Given this list of marker genes Musk, Dock2, Helz, Pak4, Sgk2, Grk6, Igf1r (insulin-like growth factor I receptor), Camk2g, Mok (MOK protein kinase), Mthfs, Camk2b, Elp1, Lats1, Myo1g, Rasgrp2, Oas3, Ccdc88a, Kif7, Pik3c2a, Adcy10, Gna12, Dync2h1, Itpr3 (inositol 1,4,5-triphosphate receptor 3), Srp54a, Elmo1, Cdk12, Gnai3, Rab2a, Tut1, Kit, Acvr1c, Hspa5, Vcp, Dgka, Mtg1, Nadk, Slc27a2, Pals1, Gnal, Camk4, Abcb11, Dnhd1, Ippk, Sh3bp5l (NCBI Gene Id 79566), Tbck, Igtp, Slc27a3, Prkcg, Rasl12, Kdr, Ephb6, Rap2c (NCBI Gene Id 72065), Galk1, Rasgrp4, Ercc6l2, Myh7b, Kif2c, Atad3a, Rab21, Atp11a, Upf1, Ttll6, Recql, Myo3a (myosin IIIA), Smc5, Rabl2, Aasdh (NCBI Gene Id 231326), Ube2k, Rap2b, Ddx46, Abl1, Epha4, Ctps1, Cit, Gbp5, Ddx51, Tor3a, Ppp5c, Acta2, Cyth4, Cmpk1, Coq8a, Tubb4a, Arhgef17, Dnaja2, Wars1, Aqr, Dhx58, Ckmt1, Palm3, Blk, Mon1a, Bmx, Ric8a, Bag5 (BCL2-associated athanogene 5), Tubb4b, Ern2, Grk1, Cdk19, Mtif2, Top2b, Nlrp9c, Ptk2b, Dgki, Rasl11a, Prkaca (NCBI Gene Id 18747), Pip5k1b, Dennd3, Tdrd9, Anxa6, Ksr2, Srpra, Fer, Abcb9 (NCBI Gene Id 56325), Mat1a, Fgr, Clcn4, Slfn8, Mapkapk3, Shpk, Csnk1a1, Pik3r4, Rnasel, Cdk17, Kif21a, Cdc42bpa, Abcd3, Rapgef5, Gbp7, Mcf2 (NCBI Gene Id 17206), Nmrk1, Dgkg, Hras, Gimap9, Renbp, Zgrf1 (NCBI Gene Id 99630), Myo3b, Ddx49, Pink1, Erbb2, Abca3, Dclk3, Nubp1, Tyro3, Pak5, Trio, Kif27, Rin3, Arf5, Uba5, Septin4, Myo10 (NCBI Gene Id 52514), D5Ertd579e, Rab14, Eef2k, Rimklb, Tsr1, Gars1, Tssk1, Eif4a3, Qrsl1, Dyrk1a, Chkb, Rasgrf2, Akt1 (NCBI Gene Id 268604), Prex2, Uprt, Afg3l1, Stk19, P2rx5, Prex1, Oxsr1, Insrr, Rab8a, Fpgt, Arl4c, Tor1b, Coq8b, Pi4k2b, Rtel1, Mast1, Dis3, Epha2, Dgkh, Clp1, Net1, Dock5, Rad51d, Kifc3, Tcp1, Tdg-ps, Yars1, Ret, Dync1li1, Gucy2e, Stradb, Atp8b2, Epha8, Abca2, Hspa13, Cct5, Stk35, Tuba8, Prkg1, Lonp2 (NCBI Gene Id 66887), Ube2d2b, Rars2, Tuba1a, Lonp1, Dnah8, Actr1b, Ercc6, Ccdc88c, Mylk, Rasgrp3, Acly, Bag4, Slc22a4, Acvr1b, Actr3, Mapkapk5, Msh6, Ksr1, Chd7, Septin10, Gbp9, Gtpbp3, Rad54l2, Vrk3, Gnat3, Dyrk4, Clk3, Atp2c1, Trap1, Insr, Rcc1l (reculator of chromosome condensation 1 like), Cps1, Tbc1d10a, Ripk4, Itpkc, Selenoo, Rgl1, Cdk1, Septin9, Runx1, Ephb2, Rangrf, Smchd1, Prps1, Tuba1b, Rabgef1, Mink1, Cct8, Srprb, Eefsec, Eef1b2, Brsk1, Plk4, Nlrp1b, Mmab, Dync1li2, Hsp90b1, Rab3b, Rapgef6, Hlcs, Atp2b1, Nadsyn1, Pik3cg, Eif2b4, Papolb, Dennd11, Dennd6a, Hspa14, Adcy1, Gimap6, Ect2, Eif2ak3, Wnk1, Uck2, Prkcz, Abcd4, Mapk10, Phkg1, Acsm2, Rab6a, Rps6ka2, Septin1, Cftr, Slc22a21, D1Pas1, Top2a, Nlrc4, Ttll3, Preb, Wee2, Fes, Pip5kl1 (phosphatidylinositol-4-phosphate 5-kinase-like 1), Farp1, Msh5, Rab20, Mcm8, Pms2, Kif20b, Rhof, Ercc2, Rtcb, Actg1, Ttll10, Magi1, Rragc, Epha3, Tubb3, Pxk, Vrk2, Gem, Arl5b, Dock8, Dnah1, Rras2, Tk2, Twnk, Itpr1, Hltf, Pak6, Ddx20, Eif2s3x, Ak8, Ckm, Mapk1, Rfk, Kif1b, Trpm6, Septin3, Ttk, Sgk1, Eif2b2, Khk, Abca12, Caprin1, Rnd3, Rhod, Kif23, Eif2b5, Dgkq, Ddx24, Msh3, Ephb3, Cdc42, Tgm2, Jak1 (NCBI Gene Id 319959), Gimap1, Lrrk2 (NCBI Gene Id 79409), Gucy2c, Ckmt2, Thrap3, P2rx7, Dennd5a, Fgd3, Als2, Dck, Acta1, Camk1d, Dhx40, Ttll7, Bcs1l, Kif24, Ino80, Kif16b, Kif4, Rab3gap2 (RAB3 GTPase activating protein subunit 2), Rhoq, Map3k6, Nek9 (NCBI Gene Id 353030), Riok1, Arhgef4, Plk2, Rabif, Rragb, Suclg2, Asns, Atp2a2, Rrm1, Eftud2, Kif2a, Baz1b, Ddx11, Pbp2, Ube2j2, Arhgef15, Arhgef6, Npr2 (NCBI Gene Id 230103), Tdg, Rtca, Smarca2, Atl2, Papss1 (3'-phosphoadenosine 5'-phosphosulfate synthase 1), Arl6, Gnl3, Adcy4, Aatk, Tuba1c, Clcn6, Rem2, Plekhg5, Acacb, Rab22a, Ak4, Gnl3l, Speg, Myh8, Stk31, Naip5, Nlrc3, P2rx2, Tnk1, Wdr41, Lck, Carns1, Ruvbl1, Arl10, Smc2, Ralgds, Mtpap, Mov10, Dnm2, Rac3, Ttll1, Raf1 (v-raf-leukemia viral oncogene 1), Bms1, Tex14, Nme1, Atp8b1, Kif14, Lars2, Rab3ip, H1f4 (H1.4 linker histone, cluster member), Chd8, Cdk2, Mx2, Ercc6l, Atp8a1, Nek7, Rab7, Rab8b, Tkfc, Ube2z, Hps4, 4933405O20Rik, Mapk9, Ripk2, Cilk1, Morc2b, Map2k3, Nav3, Dhx29, Mark3, Mlkl, Sars2, Ak2, Hk1, Rp2, Rhoa (NCBI Gene Id 51787), Srpk1, Myo7a, Entpd3, Map4k2, Septin12, Recql5, Mycbp2, Hipk4, Rab32, Wee1, Rtkn, Ralgps2, Trpm4, Map2k1, Arl8a, Ptk6, Nwd1, Pik3c2g, Kcnj8, Gpn3, Ngef, Uckl1, Top1, Actr1a, Plekhg1, Lsg1, Nadk2, Skic2, Hars2, Myo15a, Rap1b, Tssk3, Abcf1, Abcb10, Ddx21, Qars1, Rab26, Mlh1, Rngtt, Gucy1b1, Dars1, Ntrk2, Ralb, Psmc6, Adcy8 (adenylate cyclase 8), N4bp2, Ppip5k1, Dhx30, Kras, P2rx3, Atp2c2, Cplane2, Dars2, Dnah17, Agap2, Hsp90ab1, Hspa9, Stk38l, Ercc3, Atp9b, Idnk, Nubp2, Dnmbp, Eps8l3, Hkdc1, Arhgef3, Rbks, Cct2, Slc22a5, P2ry1, Dennd1c, Nlrp4f, Kcnj10, Pank2, Xrcc5, Kif11, Atp10d, Tufm, Cyth3, Pik3c3, Kif5a, Braf, Epha10, Map2k5 (NCBI Gene Id 23938), Sh2d3c, Dhx34, Nek3, Rap1a, Eif5b, Mcm5, Dennd2d, Ntpcr, Camkv, Tdrd12, Dnm3, Nlrp4b, Rab36 (NCBI Gene Id 76877), Plcd4, Dmpk, Myo5a, Ep400, Arhgef10, Adcy6, Farsa, Nsf, Chrm4, Itm2c, Adcy2, Ttll13, Afg2a, Chuk, Rlig1, Gnat2, Pars2, Atm, P2rx1, Abcg1, Slfnl1, Katnal2, Adcy7, Naip1, Abce1, Ddx3y, Map2k6, Clk1, Sergef, Prkg2, Taf1, Pomk, Epha7, Lig4, Gna13, Drg2, Smc1a, Stk36, Psd3, Agap1, Arhgef18, Arl5c, Ube2m, Ltk, Pcx, Stk32c, Peak1, Rhobtb3, Rock2, Ttll11 (tubulin tyrosine ligase-like family, member 11), Abcc1, Abcc2, Abcc4, Gucy2f, Dnaja1, Snrk (NCBI Gene Id 97116), Fn3k, Tep1, Kif5c, Tap2, Kif15, Myo18a, Uck1, Afg2b, Tlk2, Samhd1, Yars2 (tyrosyl-tRNA synthetase 2 (mitochondrial)), Ddx28, Mtg2, Rad51, Txk, Ripk1, Magi3, Sbk1, Rrad, Hfm1, Timm44 (NCBI Gene Id 76268), Erbb3, Map4k5, Cdk11b, Etnk1, Ube2n, Plekhg2, Rhov, Pikfyve, Ube2h, Gna14, Ulk1, Ptpa, Sos2, Map3k11, Abca8a, Nlrp4a, Glud1, Hacl1, Sar1b, Gspt2, Dhx15, Entpd1, Lrguk, Oas1a, Hspa4 (heat shock protein 4), Runx2, Msh4 (mutS homolog 4), Bub1b, Kif5b, Ythdc2, Rraga, Smc4, Cdkl5, Pfn1, Dock7, Gnaq, Nuak1, Mylk3, Fgfr4, Abcd1, Rps6kb1, Rasgef1c, Mccc1, Pkmyt1, Arhgap35, Arl4a (NCBI Gene Id 11861), Clcn3, Hyou1, Dnaja3, Bub1, P2ry4, Ehd2, Flad1, Adcy5, Hnrnpu, Atl1, Nin, Rasl2-9, Sil1, Map4k1, Camk2a, Arfgef3, Dyrk2, Farsb, Rnd1, Nudt2, Tor4a, Sbf1, Ikbkb, Myo6, Ppip5k2, Ddx41 (NCBI Gene Id 72935), Gch1, Ttbk1, Atp8a2, Arf1, Pcca, Gpn2, Rapgefl1, Vps4a, Dicer1, Prkag3, Myo1a, Cct3, Camk1g, Eif2b1, Fastk, Rasl11b, Smarcal1, Aacs, Gnao1, Rasd1, Itsn2, Dennd4c, Rac2, Atp4a, Ube2b, Psd, Rad51c, Mthfsl, Abca7 (NCBI Gene Id 27403), Map2k4, Tnk2, Strada (STE20-related kinase adaptor alpha), Aars1, Uba1y, Jak3, Kifc2, Matk, Entpd8, Mvd, Ddx17, Runx3, Dhx9, Papola, Rad50, Atp8b3, Mfn2 (NCBI Gene Id 170731), Sphk1, Gbp3, Irgm2, Thg1l, Gbp6, Csnk1d, Mapk6, Dnajc27, Gvin1, G3bp1, Gnas, Spag1, Cdk9, Acsf2, Gna11, Csnk1g1, Ube2frt, Slk, Pdk1, Bag1, Nubpl, Gimap7, Fcsk, Ip6k2, Hars1, Vav3, Bmpr1b (bone morphogenetic protein receptor, type 1B), Eef1a1, Acsl6, Myo1b, Smg1, Eif2ak2, Tiam2, Gtpbp4, Acsl3, Ak5, Swap70, Ddx54, Myh14, Wrn, Rnf213, Mark2, Tie1, Abcb4, Rab39b, Pkn1, Mki67, Kcnj1, Nlrp4e, Lig3, Acsl4, Madd, Syk, Tubb2b, Rap2a, Gnai2, Sik2, Nras, Scyl3, Map4k3, Ifih1, Scyl2, Gbp4, Map3k3, Pdk4, Frmd7, Map2k2 (mitogen-activated protein kinase kinase 2), Nrk, Stk16, Rgl3, Cdk15, Kifc1 (NCBI Gene Id 21656), Tssk5, Oplah, Ift27, Nme2, Nkiras1, Rhot2, Mtor, Rab11a, Acss3, Abcc5, Mknk2, Eif4a3l2, Tesk2, Zranb3, Atp13a2, Vdac1, Abcb6, Arhgef33, Sucla2, Kif3c, Nlrc5, Ehd3, Gbf1, Rfc1, Rin1, Abca1, Myo7b, Rabl6, Mx1, Ears2, Epha5, Rragd, Ttll9, Urgcp, Abcc6, Csf1r, Ddx59, Rad54b, Prkcb, Trmu, Spata13, Cad, Ube2o, Dock10, Rab10, Nmrk2, Map3k14 (mitogen-activated protein kinase kinase kinase 14), Myo1c (NCBI Gene Id 97728), Pfkfb4, Cdk7, Chd5, Nuak2, Rab4a, Mocs3, Nlk, Pkn3, Mccc2, Ube2ql1, Rab1a, Rhog, Ddx6, Ndufa13, Prkci, Myo1e, Hipk3, Ulk4, Atp2a3, Ide (insulin degrading enzyme), Acsbg2, Stk3, Opa1, Acvr2b (activin receptor IIB), Pdik1l, Fgfr2, Plekhg3, Eif4a3l1, Ctps2, Limk1, Spast, Cdk16, Ak3, Rhebl1, Map3k19, Myh4, Rps6kl1, Rab37 (RAB37, member RAS oncogene family), Arl14, Mknk1, Helz2, Prkx, Tars1, Vps4b, Riok3, Abr, Eps8l1, Glul, Smok3a, Dennd1b, Rap1gds1, Pik3ca, Dnm1, Kcnj11, Atp6v1a, Dqx1, Actr3b, Psmc2, Abcg8, Kif13a, Katnal1, Ccz1, Tubal3, Rgl2, Rab13, Sbk3, Ddx5, Kif18b, Cdkl1, Rab3d, Fbxo8 (NCBI Gene Id 50753), Limk2, Plk5, Camkk1, Psmc5, Nucb2, Abca9, Sgk3, Tent4b, Scyl1, Prkca (protein kinase C, alpha), Pbk, Acsl1 (NCBI Gene Id 56355), Tubg2, Acaca, Mastl, Rit1, Cenpe, Mapk12, Kif3a, Acss2, Myh1, Bcar3, Gtpbp10, Mov10l1, Atp13a1, Eef1d, Septin8, Syn2, Fancm, Myh3, Pdgfra, Mkks, Eif2s3y, Acsm4, Flt1, Eif2b3, Egf, Acsm3, Camk2d, Cars1, Akt2, Nmur2, Rfc5, Dhx36, Map3k4, Mark4, Trib1, Stard9, Rps6ka4, Naxd, Dnaja4, Wnk3, Srpk2, Gapvd1, Tek, Abcg2, Kif1a, Nuggc, Tssk2, Nlrp3, Gak, Ddx4 (DEAD box helicase 4), Ntrk3, Adck1, Map3k12, Mapk8, Prps2, Coasy, Map4k4, Tubb2a, Nrbp1, Pfkfb2, Smarca1, Arf4, Actg2, Ros1, Fam20c, Ube2w (ubiquitin-conjugating enzyme E2W (putative)), Rfc2, Brip1, Eif4g1, Rnf112, Stk11, Stk4, Pim2, Flt4, Tesk1, Rab30, Mvk, Prkag1, Fars2, Kif26b, Rab40b, Dapk3, P2rx6 (purinergic receptor P2X, ligand-gated ion channel, 6), Fam20b, Mcm6, Cmpk2, Uba6, Adck2, Srp54c, Cdkl4, Uba3, Fn3krp, Arhgef5, Lamtor2, Mapk4, Taok2, Pkm, Cerk, Paics, Csnk2a2, Rem1, Dock1, Rad17, Afg1l, Tpk1, Dapk1, Rab39, Ciita, Dock6, Rab3c, Chd6, Prkch, Pfkm, Tuba3a, Bmp2k, Atp1a3, Bag2, Fgfr3, Gmppb, Arhgef38, Map3k21, Bag3, Twf2, Rab33a, Kif17, Psmc4, Rasgrp1, Slc12a4, Nars2, Iqsec2, Hsp90aa1, Prag1, Fgfr1, Hspa1l, Arfgef1, Ric8b, Gart (phosphoribosylglycinamide formyltransferase), Ddx31, Dhx57, Ddx50, Arhgef1, Dguok (NCBI Gene Id 27369), Stk33, Cdk20, Trp53rkb, Abcb1b, Sars1 (NCBI Gene Id 97063), Iars1, Septin11, Srms, Septin5, Alpk2, Mrgpra1, Ddx27, Ran, Gm7168, Chka, Cdk8, Ckb, Nek11, Papss2, Erbb4, Mras, Acsf3, Map3k20, Acss1, Als2cl, Kif21b, Tssk6, Met, Stk17b, Rab3gap1, Eif2ak4, Styk1, Rab12, Ube2d1, Smc3, Rab24, Rala (v-ral simian leukemia viral oncogene A (ras related)), Itpr2, Guk1, Nrbp2, Ddr2, Itpka, Get3, Gne, Ikbke, Nek6, Rasgrf1, Rab42, Abca6, Taok3, Drg1, Recql4, Grk3, Phkg2, Dgkz, Prkdc, Dgkd, Tgtp1, Grpel2, Ddx42, Bckdk, Ttbk2, Acvrl1, Epha1, Trpv4, Dock11, Pstk, Etnk2, Dync1h1, Xrcc2, Rcc1, Ighmbp2, Atp9a, Rps6ka6, Trim23, Septin6 (NCBI Gene Id 80615), Ddx19a, Eif5, Atp11b, Chordc1, Eif2ak1 (NCBI Gene Id 15467), Kif18a, Mthfd1l, Adss2, Cars2, Map3k8, Smok2b, Dnm1l, Myh9, Rheb, Smok3b, Dennd1a, Rab43, Fbh1, Abca13, Dhx32, Atrx, Gbp2b, Plekhg6, Prkag2, Ilk, Mars1, Septin7, Adcy9 (NCBI Gene Id 28001), Arhgef10l, Rad54l, Atp13a3, Rabl3, Pan3, Kif1c, Myo9a, Gphn, Rpgr, Psmc3, Ulk3 (NCBI Gene Id 71742), Gucy1a1, Fpgs, Irgq, Pak2, Rfc4, Dalrd3, Pif1, Ptk7, Oas2 (2'-5' oligoadenylate synthetase 2), Cdk5, Dnah12 (dynein, axonemal, heavy chain 12), Snrnp200, Ror2, Dclk2, Abcf2, Cdk18, Abcc3, Bcr, Rab35, Rab5a, Ak1, Nucb1, Eras, Atp1a1, Supv3l1, Arf6, Nek8, Sec61b, Ube2j1, Ephb4, Gimap3, Ttl, P2rx4, Nme7, Xrcc3, Ttf2, Arhgef16, Pccb, Rab31, Smc1b, Trnt1, Npm1 (nucleophosmin 1), Cdc34, Ddx10, Gk2, Mars2, Mapk11, Ube2f, Eif4a2, Gm12250, Tubb6, Ube2d3, Dnah3, Rasgef1b, Irgc, Mcf2l, Cdc42bpg, Psd4, Dhx8, Helq, Stk40, Dennd5b, Abcb1a, Abcc8, Kif26a, Sik1, Mat2a, Helb, Gimd1, Gimap5, Mapk14, Nlrp12, Vav2, Pmvk, Yes1, Rasd2, Plk1, Aldh18a1, Mcm9, Sbf2, Hsph1, Map3k5, Ube2i, Dgkb, Twf1, Ulk2, Cacna1b, Smc6, Pip5k1c, Stk10 (serine/threonine kinase 10), Atad5, Arl5a, Papolg, Camkk2, Nol9, Zng1, Hunk, Rab38, Fgd1, Lig1, Rab33b, Pebp1, Sephs1, Orc5, Nlrp9a, Pdxk, Nek1, Dtymk, Rab1b, Adcy3, Map3k13, Aurkc (aurora kinase C), Irak2, Atr, Abcb7, Ddx18, Hspa12a, Cdk10, Atp8b5, Itsn1, Adss1, Abcd2, Zap70, Rab4b, Plcg1, Clpb, Ube2a, Mfhas1, Nod2, Lamtor1, Tec, Prpf4b, Rcc2, Cyth2, Camk1, Tnik, Hbs1l, Arhgef25, Iqca1, Nlrp4c, Hspe1, Ric1, Ube2e1, Pank1, Actr8, Ror1, Rhoj, Obscn, Mast4, Arf2, Cdk6, Dnah2, Iigp1, Uhmk1, Arhgef12, Ube2l6, Orc4, Gspt1, Nagk (NCBI Gene Id 56174), Oasl2, Rac1 (Rac family small GTPase 1), Araf, Srxn1, Rab3a, Iqsec3, Shprh, Arl13a, Dock3, Rapgef4, Rab2b, Mtrex, Actr2, Mylk4, Vav1, Tssk4, Mark1, Rab34, Chd9, Gimap4, Csnk2a1, Hck, Actc1, Kndc1, Trit1, Cdkl2, Pank3, Tars3, Gnaz, Tgfbr2, Abcb8, Pfas, Nlrp5, Ttll8, Dennd4b, Smarca5, Atp1a4, Ddx25, Ddx55, Ankk1, Dstyk, Acsbg1, Map2k7, Nlrp10 (NLR family, pyrin domain containing 10), Axl, Smok2a, Stk38, Atp6v1b1, Gbp10, Rab25, Grk2, Tubg1, Rab15, Fyn (Fyn proto-oncogene), Acvr1, Rps6ka5, Pgk2, Rab7b, Hhat, Fign, Acsm1, Pip4k2c, Tgtp2, Cul9, Abcc9, Pklr, Gfm1, Rab27a, Tor1a, Stk-ps2 (serine/threonine kinase 2), Clpx, Clk4, Acvr2a, Rapgef1, Rin2, Smcr8, Dnah5, Idh3g, Chek2, Gucy2d, Dennd10, Gck, Spo11, Srp54b, Arl15, Csnk1g3, Acsl5, Chd1l, Rab29, Csnk1e, Epha6, Eps8l2, Gdpgp1, Cracr2a, Mylk2, Hk2, Naip6 (NCBI Gene Id 272660), Iqsec1, Mak, Ehd1, Septin14, Dock4, Ddx39a, Bmpr1a, Ube2l3, Gm266, Mapkapk2 (NCBI Gene Id 98242), Map3k9, Ralgps1, Pak3, Fgd4, Pip4k2a, Slc38a9, Arfgef2, Riok2, Grk4, Atp10a, Ddr1, Fignl1, Tiam1, Pak1, 4921509C19Rik, Stk32a, Gfm2, Nek10, Entpd2, Sar1a, Tent4a, Dyrk1b, Rigi, Abcc12, Alk, Grpel1, Mcm3, Dclk1, Stk25, Ddx47, Arfrp1, Myh6 (myosin, heavy polypeptide 6, cardiac muscle, alpha), Rhob, Cdk13, Ern1, Prkcd, Rasl10a, Hspa4l, Mertk, Trpm7 (NCBI Gene Id 80648), Kif22, Tnni3k, Abcg4, Chtf18, Vars1, Gucy2g, Clk2, Gss, Ucp1, Tubd1, Ube2e2, Abcc10, Nme6, Fgd5, Arl2 (ADP-ribosylation factor-like 2), Myo1f, Gtpbp8, Melk, Dapk2 (death-associated protein kinase 2), Mcm4 (NCBI Gene Id 17217), Prkd1, Trib3, Arl1, Cdc42bpb, Rasgef1a, Vdac2, Abca4, Dyrk3, Ascc3, Rit2, Rimkla, Rab44, Pi4ka, Kif28, Agk, Pim3, Slc12a3 (NCBI Gene Id 20497), Aurkb (aurora kinase B), Rictor, Tlk1, Cgas, Flt3, Ficd, Rskr, Rab6b, Aarsd1, Dennd6b, Pgs1, Myo1h, Kars1, Rab5b, Glyctk (glycerate kinase), Gpn1, Ass1, 4930544G11Rik, Vwa8, Plce1, Rras (NCBI Gene Id 20130), Rasl10b, Hspa8, Rps6kc1, Sos1, Dmc1 (NCBI Gene Id 13404), Wnk2, Dcakd, Sbk2, Nlrp9b, Nmnat3, Atp2b4 (ATPase, Ca++ transporting, plasma membrane 4, NCBI Gene Id 381290), Rab18 (RAB18, member RAS oncogene family), Gripap1, Pfkp, Ola1, Cct6a, Ube2c, Tent2, Katna1, Ankrd27, Ube2d2a (ubiquitin-conjugating enzyme E2D 2A), Alpk3, Gna15, Jak2, C9orf72, Rab27b, Clcn5, Rgp1, Bbs10 (Bardet-Biedl syndrome 10), Abca5, Spg7 (SPG7, paraplegin matrix AAA peptidase subunit), Atp12a, Noa1 (NCBI Gene Id 67056), Aurka, Agap3, Kif3b, Sphk2, Setx, Rapgef2 (NCBI Gene Id 76089), Chek1, Hipk2, Nars1, Dph6, Nlrx1, Uba1, Stk26, Vps9d1, Arl4d, Eral1, Dgke, Kif9, Prkd2 (NCBI Gene Id 232912), Hspa1b, Alpk1, Rab28, Rab9b, Pcp2, Rock1, Diras1, Entpd6, Pip5k1a, Bmpr2, Mst1r, Pck1, Wrnip1, Hspbp1, Mapk15, Tbk1, Pex1, Rhou, Ube2s, Btk, Prkaa1, Ryk (receptor-like tyrosine kinase), Atp6v1b2, Rab11b, Ttll5, Acot12, Nlrp14, Dennd2b, Pnck, Gatb, Atp7a, Gnl1, Mcm7, Trip13, Ube2t, Lamtor4, Map3k1, Tap1, Rhoh (NCBI Gene Id 74734), Sephs2, Tubb1, Kti12, Ttn, Lmtk2, Arl3, Nek4, Abca17, Pim1, Fkbp4, Rab9, Lmtk3, Map3k2, Gbp8, Ddx3x, Apaf1, Ranbp10, Ntrk1, Pik3cd, Mos, Abca8b, Arhgef40, Dennd2a, Rab40c, Kif19a, Yme1l1, Hspd1, Enpp3, Pi4k2a, Ttll2, Ip6k3, Ube4b, Frk, Csk, Itpk1, Gmps, Amhr2, Mapk3, Abl2, Rab3il1, Aak1, Brsk2, Atp2b2, Atp2a1, Hells, Rad51b, Cct7 (chaperonin containing TCP1 subunit 7), Chd4 (NCBI Gene Id 77403), Irgm1, Nek2 (NIMA (never in mitosis gene a)-related expressed kinase 2), Nlrp1a, Ddx39b, Ephb1, Atp13a5, Gimap8, Stk32b, Nvl (nuclear VCP-like), Gatc, Fgd2, Cdk4, Src, Xrcc6, Tubb5, Ptk2, Pdk2, Arhgef39, Nkiras2, Hps1, Pex6, Rab17 (NCBI Gene Id 98692), Lats2, Pskh1, Pfkl, Arl8b, Atp11c, Farp2, Trpv1, Tuba4a, Ripk3, Taok1, Ddx52, Slfn5, Ube2g2, Rhoc, Ift22, Aars2, Akap13, Dock9, Rasef, Wars2, Arhgef37, Srl, Pkdcc, Prkcq, Dennd2c, Guf1, Atp5f1b, Myo9b, Irak1, Cdc6, Gbp2, Arhgef28, Arhgef9, Pask, Ube2g1, Nmnat2, Mcm2, Vars2, Eif4a1, Fgd6, Stk39, Orc1, Gk, Ube2r2, Atp13a4, Pank4, Tyk2, Eef1a2, Myh11, Rhobtb1, Xylb, Atad1, Slc27a5, Csnk1g2, Tars2, Rerg, Npr1, Ak6, Myo19, Rnd2, Gnai1, Rars1, Nod1, Nek5, Tgfbr1, Pkn2, Ttll4, Atl3, Ube2e3, Uba2, Pdgfrb, Rps6kb2, Rab5c, Efl1, Myh7, Arl11, Dcaf1, Adk, Nim1k, Kif20a (kinesin family member 20A), Prkd3, Syn3, Rapgef3, Rps6ka3, Stk24, Atp10b, Ip6k1, Mast3, Ak7, Blm, Gtpbp6, Dennd4a, Arhgef11, Diras2, Msh2, Atad2, Plk3, Pygl, Cdc123, Hspa2, Nme3, Arf3, Srpk3, Iars2, Lamtor5, Gtpbp1, Clcn7, Pgk1, Mthfd1, Mcmdc2, Tube1, Slfn9, Pik3cb, Kif2b, Lyn, Haspin, Gnat1, Nme4, Abcg5, Prkacb, Hspa12b, Gsk3a, Mast2, Wnk4, Cdkl3, P2ry2, Afg3l2, Actb, Mmaa, Mocs1, Psd2, Stkld1, Ube2q2 (NCBI Gene Id 76838), Rhot1, Ehd4, Smarca4, Pip4k2b, Vrk1, Dhx33, Abcf3, Myo1d, Mfn1, Chd1, Hcar2, Eprs1, Gnl2, Ppcs, Pdk3, Polq, Ryr1, Pck2, Rps6ka1 (ribosomal protein S6 kinase polypeptide 1), Galk2, Prkce (NCBI Gene Id 98094), Arhgef7, Pfkfb1, Gsk3b, Eef2, Lrrk1, Nat10, Enpp1, Srr (NCBI Gene Id 27364), Naip2, Bbs12, Sh3bp5, Kalrn, Atp5f1a, Gclc, Septin2, Cask, Deptor, Sik3, Syn1, Rab23, Iqca1l, Ddx1, Acsm5, Egfr, Akt3, Morc2a, Mapk13, Grk5, Psmc1, Ttll12, Hipk1, Tor2a, Map3k15, H1f7, Cyth1, Hk3, Irak4, Tagap, Myo16, Abcg3, Cdk14, Ruvbl2, Pnkp, Cct6b, Actbl2, Nt5c2, Hspa1a, Itm2b, Tk1, Atp7b, Map3k7, Arl13b, Lars1 (leucyl-tRNA synthetase 1), Arhgef19, Mapk7, Abcb5, Ube2q1, Rhobtb2, Cnnm2, Rab19, Chd2, Gk5 (glycerol kinase 5), Gm4922, Prkaa2, Ipmk, Pdpk1, Ddx56, Lamtor3, Myo5b (myosin VB), Cct4, Irak3, Nlrp6, Ralbp1, Cdc7, Map3k10, Gtpbp2, Kif12, Nmnat1, Myh10, Arhgef2, Rinl, Smarcad1, Itk, Atp1a2, Pi4kb, Dna2, here is a description of the gene set: Mouse Gene Set: GOMF_PURINE_RIBONUCLEOSIDE_TRIPHOSPHATE_BINDING Binding to a purine ribonucleoside triphosphate, a compound consisting of a purine base linked to a ribose sugar esterified with triphosphate on the sugar. studied in species Mus musculus